The following is a description of a gene set: The lipid bilayer surrounding any of the compartments that make up the cis-Golgi network. species: Homo sapiens Human Gene Set: GOCC_CIS_GOLGI_NETWORK_MEMBRANE, and this is the list of marker genes: RNF183, TRAPPC3, ATP2C1, PMEL, VPS13B, HLA-G, RAB18, TRAPPC3L, BOK, GPR108, TMEM165, RAB30